The following is a description of a gene set: studied in species Mus musculus The directed movement of a vesicle along a cytoskeletal fiber such as a microtubule or and actin filament, mediated by motor proteins. Mouse Gene Set: GOBP_VESICLE_CYTOSKELETAL_TRAFFICKING, and this is the list of marker genes: Kif5a, Fyco1, Borcs5, Trim46, Fbxw11, Ppfia2, Ap3b1, Kifc1, Prkcz, Kif5b, Kif16b, Pafah1b1, Bloc1s4, Kif1c, Madd, Kif1b, Ap3d1, Ap3s1, Bicdl1, Myo5a, F8a, Ap3s2, Ccdc186, Sybu, Map2, Myrip, Trak2, Dync1i1, Bloc1s1, Ap3m2, Wasl, Kif1a (kinesin family member 1A), Nde1, Map2k1, Bloc1s6, Myo1c, Rasgrp1, Kif13a, Hap1, Bloc1s2, Ap3m1, Mecp2, Tanc2, Ap3b2, Snapin, Stk11, Actn4, Dtnbp1, Rab1a, Fnbp1l, Kif28, Syt4, Bicdl2, Cln3, Cnih2, Spg11, Trak1, Htt, Bloc1s3, Bloc1s5, Ndel1